The following is a description of a gene set: Mouse Gene Set: WAKABAYASHI_ADIPOGENESIS_PPARG_RXRA_BOUND_WITH_H4K20ME1_MARK species: Mus musculus from publication Wakabayashi K, Okamura M, Tsutsumi S, Nishikawa NS, Tanaka T, Sakakibara I, Kitakami J, Ihara S, Hashimoto Y, Hamakubo T, Kodama T, Aburatani H, Sakai J (PMID 19414603) Genes with promoters bound by both PPARG and RXRA at 8 (but not 0) day time point of adipocyte differentiation of 3T3-L1 cells (preadipocyte) and that were newly modified by H4K20me1. Control of cell differentiation occurs through transcriptional mechanisms and through epigenetic modification. Using a chromatin immunoprecipitation-on-chip approach, we performed a genome-wide search for target genes of peroxisome proliferator-activated receptor gamma (PPAR gamma) and its partner protein retinoid X receptor alpha during adipogenesis. We show that these two receptors target several genes that encode histone lysine methyltransferase SET domain proteins. The histone H4 Lys 20 (H4K20) monomethyltransferase PR-Set7/Setd8 gene is upregulated by PPAR gamma during adipogenesis, and the knockdown of PR-Set7/Setd8 suppressed adipogenesis. Intriguingly, monomethylated H4K20 (H4K20me1) levels are robustly increased toward the end of differentiation. PR-Set7/Setd8 positively regulates the expression of PPAR gamma and its targets through H4K20 monomethylation. Furthermore, the activation of PPAR gamma transcriptional activity leads to the induction of H4K20me1 modification of PPAR gamma and its targets and thereby promotes adipogenesis. We also show that PPAR gamma targets PPAR gamma2 and promotes its gene expression through H4K20 monomethylation. Our results connect transcriptional regulation and epigenetic chromatin modulation through H4K20 monomethylation during adipogenesis through a feedback loop., and this is the list of marker genes: Dgat1, Alad, Hibch, Abhd1, Plaat3, Tmem33, Slc48a1, Evi5l, Gcsh, Qdpr, Scd1, Lsm12 (NCBI Gene Id 68741), Gprc5b, Lpl, Lin52, Ormdl3, Slc25a46, Ppm1b (protein phosphatase 1B, magnesium dependent, beta isoform), Mocs2, Agpat2, Chchd3, Eeig1 (NCBI Gene Id 98952), Pank3, Ifngr1, Nr1d1, Pla2g15, Pcx, Nfe2l1, Reep5, Pcyox1, Pcca, Cd302, Atg101, Xrcc3, Ginm1, Sfxn1, Hsd17b12, Atp1b3, Etfb, Atn1, Ltbp3, Msmo1, Atp5mc3, Atosa, Lipe, Hsdl2, Dram2, Plod1, Cers4, Ttyh2, Tank, Pex5, Hibadh, Adipor2, Adamts12, Tmcc3, Fam13a, Erp29, Slc66a3, Klhl25, Atp5pf, Dab2ip, Coq8a, Rasa3, Fads2, Cyrib, Nabp1, Natd1, Jagn1, Kat2b, Mtus1, H2bc4, Ypel5, Abcc4, Slc1a5, Acox1, Cs, Acsl3 (NCBI Gene Id 96921), Cyth1, Immt, Mpc2, Fdx1 (NCBI Gene Id 14148), Abhd15, Aox1, Ptgr2, Pxmp4, Gucd1, Zfp219, Parl, Acadm, Selenop, Plcb1, Stom (NCBI Gene Id 227754), Acaa2, Bcar3, Aldh6a1, Pnpla2, Mtch2, Mknk2, Zfp386, Apmap, Pex3, Csad, Ndufs6, Klf15, Ksr1, Bcl2l13, Lrrc8d, Aftph, Pparg, Plekhf2, Selenoi, Esrra, Adipoq, Eif4g3, G3bp2, Chpt1, Tob2, Cpeb3, Scarb2, Ap3s1, Txlng, Fabp4, Mlf2, Kmt5a, Ncbp1, Bfar, Fbxo8 (NCBI Gene Id 50753), Chp1, Prnp, Baz2a, Nmt1, Pfkl, Mapkbp1, Pus10, Scaf1, Ghitm, Idh1, Cerk, Pam16, Efr3a (EFR3 homolog A), Hadh, Bcat2, Pla2g6, Pfkfb1, Sort1, Pim3, Lonp2